Given this list of marker genes EREG, AREG, TGFA, BTC, EPGN, EGF, HBEGF, EGFR (NCBI Gene Id 1956), here is a description of the gene set: Reactome Pathway: Inhibition of Signaling by Overexpressed EGFR part of: Signaling by Overexpressed Wild-Type EGFR in Cancer species: Homo sapiens Recombinant monoclonal antibody Cetuximab acts as an antagonist of EGFR ligand binding, and is approved for the treatment of tumors that over-express wild-type EGFR receptor. Effective concentrations of covalent tyrosine kinase inhibitors (TKIs) inhibit wild-type EGFR, causing severe side effects. Hence, covalent TKIs have not shown much promise in clinical trials (Reviewed by Pao and Chmielecki in 2010).